The following is a description of a gene set: from publication Chen Y, Wang X (PMID 31504780) Genes predicted to be targets of miRBase v22 microRNA mmu_miR_6348 in miRDB v6.0 with MirTarget v4 prediction scores > 80 (high confidence targets). Mouse Gene Set: MIR_6348 studied in species Mus musculus, and this is the list of marker genes: Zc3h4, Abcb10, Trub2, Atrx (NCBI Gene Id 67403), Plcxd1, Vcpip1, Slc25a34, Sprr2b, Alad, Phf21a, Flad1, Synpo2, Tmem47, Dhx40, Txk, Zfyve26, Wdr24, Snrpb, Mmp24, Mex3c, Usp9x, Cdr2, Jaml, Nadk2, Hoxd1, Npepps, Adtrp, Negr1, Upk2 (NCBI Gene Id 22269), Cldn19, Ildr2, Tmem39a, Zic3, Tfdp2, Itk, Fmr1, Cnst, 6430548M08Rik, Lipt1, Mal, Fgf7 (fibroblast growth factor 7), Clns1a, Rbms1, Cap1, Mpp7, Fgf10, Tmem131, Parp3, Ppp4r3b, Ergic1, Cnih3, Tmx1, Ipo8, Zcchc18, Septin10, Barx2, Zfp280c, Drp2, Ap4e1, Trabd2b, Mief1, Med14, Rfwd3, Hivep3, Pik3cg, Zfc3h1, Mgat1, Prex1, Ttc1, Slc4a5, Grpel2 (GrpE-like 2, mitochondrial), Arpp21, Slc6a8, Gm5820, Pif1 (NCBI Gene Id 208084), Kdm6a (NCBI Gene Id 22289), Sdad1, Klhl4, Hcn1, Gpr162, Rras2, Ddit4l, Akirin1 (akirin 1), Sash3, Fgf12, Chid1, Traf6, Tnrc6b, Pde1a, Sgip1 (NCBI Gene Id 73094), Larp1, Gypa, Cbln1, Serinc5, Gm11544